The following is a description of a gene set: studied in species Homo sapiens Binding to a DNA polymerase. Human Gene Set: GOMF_DNA_POLYMERASE_BINDING, and this is the list of marker genes: POLG2, LONP1, TERC, SMG6, HNRNPA2B1, ACD, NAT10, FANCD2, CDK2AP1, RAD51, FANCI, NHEJ1, HSP90AA1, CDT1, SMARCA4, PCNA, PAXX, HSP90AB1, NABP2, PTGES3, RTEL1, HMGB1